The following is a description of a gene set: Facial contour, as viewed from the front, triangular in shape, with breadth at the temples and tapering to a narrow chin. Triangular face Human Gene Set: HP_TRIANGULAR_FACE species: Homo sapiens, and this is the list of marker genes: SEC61A1, PYCR1, IFITM5, CAV1, RNU4-2, KRAS, BUB1B, GJA5, SEC31A, UNC80, ALDH18A1, NONO, SOX6, AP1S2, ANKRD17, ATP6V1E1, PEX19, MED12, NOTCH2, PPP2R5D, SPRED2, FBLN5, SPRED1, GJA8, SLC45A1, POLR3A, SCUBE3, PUS7, SMARCAL1, HUWE1, TRMT5, RIT1, TRPS1, LZTR1, LEMD2, INTS11, TRIP13, FKBP10, MRAS, MAFB, SOS1, PAX7, CDK10, SERPINH1, RERE, HMGA2, CTCF, EPG5, PAPPA2, NALCN, HERC1 (HECT and RLD domain containing E3 ubiquitin protein ligase family member 1), CLCNKA, COL1A1, GMPPA, ERI1, MYCN, PTPN11, CUL7, ADGRG6, FANCC, SMC1A, CEP57, ORC6, KCNJ5, SMC5, SPRTN, ESAM, IGF1R, ZMYM2, PRKG2, SEC24D, B9D1, CCDC8, PQBP1, KAT6A, GRB10, COL1A2 (NCBI Gene Id 1278), TNNI2, SLC25A24, PEX14, FANCI, PEX13, ELN, TNRC6B, LARP7, BSCL2, MAP2K1, MCTP2 (multiple C2 and transmembrane domain containing 2, NCBI Gene Id 55784), KCNJ1, FBXO11, NRAS, BRAF, ATP6V1A, TMEM94, TRIM37, MED12L, BPTF, PTF1A, RRAS, PIK3R1, MTX2, CLCNKB, TOMM7, BMP1, PYCR2, FOCAD, RAP1GDS1, BSND, EMC10, SIN3A, PPIB, SPOP, FLCN, ARX, GBA1, CBL, TBX2, TNNT3, BUB3, PRPS1, CDKN1C, KCNJ2, FILIP1, SOS2, NSD1 (nuclear receptor binding SET domain protein 1), NECTIN1 (NCBI Gene Id 84853), PIEZO2, SCARF2, JARID2, MVK, POC1A, MYH3, H4C5, RAI1, MED13L, TALDO1, DCAF17, XRCC4, RASA2, ZNF699 (NCBI Gene Id 374879, zinc finger protein 699), ZNF148, EBF3, OBSL1, RAF1, BUB1, STAG2, RRAS2, IGF2, SYNGAP1, H19, ALG12, PSMD12, SMARCA2, ANKRD11, HS6ST2, MYOD1, FBN1, AGPAT2 (1-acylglycerol-3-phosphate O-acyltransferase 2), TAOK1, JAG1, ERCC6, NFIX, PLAG1, FRA10AC1, SRCAP, LEMD3, PLOD2, CDC6